The following is a description of a gene set: studied in species Homo sapiens Inositol phosphate metabolism Human Gene Set: REACTOME_INOSITOL_PHOSPHATE_METABOLISM, and this is the list of marker genes: PLCG1, PLCD3, INPP4B, INPP5J, INPP5D, INPP5A, PLCD4, ITPKC, PLCH1, PPIP5K2, PLCB3 (phospholipase C beta 3), NUDT4, ITPKA, INPP5B, MTMR7, IP6K1, IP6K2, NUDT10, ITPK1, MINPP1, NUDT3, ISYNA1, INPPL1, IP6K3, IMPA2, PLD4, IMPA1, CALM1, PLCZ1, IPMK, ITPKB, MTMR9, PLCE1, SYNJ1, PTEN, PPIP5K1, PLCB1, INPP1, PLCD1, INPP4A, OCRL, PLCG2, IPPK, PLCB4, PLCH2, NUDT11, MIOX, PLCB2